The following is a description of a gene set: studied in species Homo sapiens Binding to a SH3 domain (Src homology 3) of a protein, small protein modules containing approximately 50 amino acid residues found in a great variety of intracellular or membrane-associated proteins. Human Gene Set: GOMF_SH3_DOMAIN_BINDING, and this is the list of marker genes: BCAR1, CIT, PLSCR4, EPS15, LRP2, SOCS7, AKAP5, PLSCR3, DNAJC6, QKI, TOM1L1, CBL, INPP5J, ADAM15, WASF2, PTTG1 (PTTG1 regulator of sister chromatid separation, securin), WIPF1, SH3BGRL, DOCK1, USP8, CBLC, HCLS1, MAPT (microtubule associated protein tau), CD3E, MAPK15, NOXA1, SYNGAP1, ARHGAP6, UVRAG, CCDC6, KHDRBS3, FUT8, ITGB1BP2, ABL1, DOCK3, ELMO1, PTPN12, DRD4, ADAM12, SH3BP1, ARHGAP1, CRB3, SHANK3, ACP1, ADAM19, VASP, ADAM10, CNTNAP1, CYBA, SH2D2A, REPS1, MVB12A, RUFY2, KHDRBS2, ELMO3, MYPN, INPPL1, KHDRBS1, SH3BGR, DPYSL3, SKAP1, SHANK1, ENKUR, LANCL1, TP53BP2, ELMO2, ABI1, CTTNBP2 (NCBI Gene Id 85447), CASP9, ESPN, LYN, PTTG3P, DOCK4, MICAL1, RAD9A, DTX1, NCKIPSD, INPP5D, AFAP1L2, EFS, GPX1, SH3BP5, DAB2IP, PTTG2, ARHGAP31 (NCBI Gene Id 57514), PAK3, SIRPA, ERRFI1, NCF1, SOS1, EVL, PTPN6, SGIP1, ADAM9, PLSCR1, RAPGEF1, ARHGAP27, ADAM17, CD2AP, PRKN, GRB2 (NCBI Gene Id 80715), ARHGAP17, OSTF1, DNM2, CRK, HIP1R, ABI2, SH3KBP1, RUFY1, SHANK2, PTPN22, WAS, SH3BP2 (NCBI Gene Id 91018), CABYR, SH3BGRL2, ENAH